The following is a description of a gene set: studied in species Mus musculus Mouse Gene Set: GOBP_NEGATIVE_REGULATION_OF_AUTOPHAGY_OF_MITOCHONDRION Any process that stops, prevents or reduces the frequency, rate or extent of mitochondrion degradation by autophagy., and this is the list of marker genes: Tspo, Pink1 (PTEN induced putative kinase 1), Pptc7, Usp30, Clec16a, Htra2, Trp53, Tigar, Fbxl4, Rnf41, Vps13c